Given this list of marker genes Pcsk1, Irak2, Mmp2, Il1rap, Il1r2, Rbmxl1, Ythdc2, Slc30a8, Irak4, Fn1, Ep300, Tnip2, Yy1, Taf9, Snca, Pck1, Upf1, Cxcl2, Hes1, Hif1a, Smpd1, Cactin, St18, Sox9, Traf6, Src, Acod1, Dab2ip, Mapk13, Chi3l1, Serpine1, Cited1, Il1r1, Pycard, Hyal2, Irf1 (interferon regulatory factor 1), Sirpa, Prkca, Il1rl2, Rps6ka4, Tle5, Ripk2, Rc3h1, Il1rn, Tnfrsf11a, Ccl5, Nfkbia, Kmo, Gclc, Otud4, Tollip, Ikbkb, Fgb, Cebpb, Inhbb (NCBI Gene Id 16324), Vrk2, Irak3, Zbp1, Hyal3, Hdac4, Map2k7, Adamts7, Zc3h12a, Klf2, Rbmx, Il6, Tank, Adamts12, Ankrd1, Camp, Saa3, Rps6ka5, Egr1, Bmi1, Has2, Akap12, Usp10, Rora, Il1b, Myd88, Ccl2, Prkci, Nr1d1, Sigirr, Rela, Il17a, Sele, Hnmt, Tirap, Cd38, Plcb1, App (amyloid beta precursor protein), Ptgis, Mapk11, Ikbip, Nfkb1, Cfl1, Nkx3-1, Hyal1, Edn1 (NCBI Gene Id 13614), Sfrp1, Irak1, Cd47, Epo, Mylk3, Mapk3, here is a description of the gene set: studied in species Mus musculus Mouse Gene Set: GOBP_RESPONSE_TO_INTERLEUKIN_1 Any process that results in a change in state or activity of a cell or an organism (in terms of movement, secretion, enzyme production, gene expression, etc.) as a result of an interleukin-1 stimulus.